Given this list of marker genes Mstn, Carmil2, Arpc2, Coro1b, Coro1c, Arpin, Capzb, Mtor, Cfl1, Was, Nckap1, Wasf2, Twf2, Abi3, Aqp1, Plxnb3, Rac1, Vil1, Hdac4 (histone deacetylase 4), Atp7a, Src, Cdc42, Pik3r1, Frmd7, Dnm2, Epha2, Actr3, Actr2, Fer, Twf1, Bin3, Kank1, Enpp2, Hrg, Dmtn, Fscn1, Wnt1, Clrn1, Avil, Abi2, Carmil1 (NCBI Gene Id 68732), Cyfip1, Brk1, Plce1, Cd44, Akirin1, Rreb1, Pdpn (podoplanin), Rac2, Hsp90aa1, Slit2, Auts2, here is a description of the gene set: species: Mus musculus Any process that modulates the frequency, rate or extent of lamellipodium organization. Mouse Gene Set: GOBP_REGULATION_OF_LAMELLIPODIUM_ORGANIZATION